Given this list of marker genes STAT1, FN1, PPP2R2A, ITGB1, NLRP3, PPP2R1B, PPP2CA, IKBKB, PDE4D, NFKBIA, CHUK, PTPN1, ITGA5, YAP1, PIEZO1, CAPNS1 (NCBI Gene Id 826), GNAQ, ITGB3, IKBKE, ABL1, PTK2 (protein tyrosine kinase 2), IKBKG, PPP2R1A, VCL, CAPN2, ANXA2 (annexin A2), CAPNS2, RELA, GNA11, ITGAV, NFKB1, here is a description of the gene set: species: Homo sapiens Human Gene Set: REACTOME_TURBULENT_OSCILLATORY_DISTURBED_FLOW_SHEAR_STRESS_ACTIVATES_SIGNALING_BY_PIEZO1_AND_INTEGRINS_IN_ENDOTHELIAL_CELLS Turbulent (oscillatory, disturbed) flow shear stress activates signaling by PIEZO1 and integrins in endothelial cells